Given this list of marker genes ALDH5A1, RFC3, LHFPL6, SLC35E3, LEF1, HADH, BMP7, RCBTB1, HNRNPA3, DLEU1, NASP, RAP1GAP2, FHOD3, PTBP2, WASF1, MME, RGCC, PDCD4-AS1, TUBB2A, TCF3, APBB2, SUGCT, BACH2, TCL6, ID3, CSE1L, SOX11, TFDP2, SERINC5, TERT, TUBA1A, SSBP2, RNASEH2B, NSG1, VPREB1, PRDM10, PRKAR2B, ATP5MJ, LZTS1, SMARCA4 (NCBI Gene Id 6597), UCHL1, TUBB2B, TCP1, here is a description of the gene set: BACKGROUND: The distinction between Burkitt's lymphoma and diffuse large-B-cell lymphoma is unclear. We used transcriptional and genomic profiling to define Burkitt's lymphoma more precisely and to distinguish subgroups in other types of mature aggressive B-cell lymphomas. METHODS: We performed gene-expression profiling using Affymetrix U133A GeneChips with RNA from 220 mature aggressive B-cell lymphomas, including a core group of 8 Burkitt's lymphomas that met all World Health Organization (WHO) criteria. A molecular signature for Burkitt's lymphoma was generated, and chromosomal abnormalities were detected with interphase fluorescence in situ hybridization and array-based comparative genomic hybridization. RESULTS: We used the molecular signature for Burkitt's lymphoma to identify 44 cases: 11 had the morphologic features of diffuse large-B-cell lymphomas, 4 were unclassifiable mature aggressive B-cell lymphomas, and 29 had a classic or atypical Burkitt's morphologic appearance. Also, five did not have a detectable IG-myc Burkitt's translocation, whereas the others contained an IG-myc fusion, mostly in simple karyotypes. Of the 176 lymphomas without the molecular signature for Burkitt's lymphoma, 155 were diffuse large-B-cell lymphomas. Of these 155 cases, 21 percent had a chromosomal breakpoint at the myc locus associated with complex chromosomal changes and an unfavorable clinical course. CONCLUSIONS: Our molecular definition of Burkitt's lymphoma clarifies and extends the spectrum of the WHO criteria for Burkitt's lymphoma. In mature aggressive B-cell lymphomas without a gene signature for Burkitt's lymphoma, chromosomal breakpoints at the myc locus were associated with an adverse clinical outcome. from publication Hummel M, Bentink S, Berger H, Klapper W, Wessendorf S, Barth TF, Bernd HW, Cogliatti SB, Dierlamm J, Feller AC, Hansmann ML, Haralambieva E, Harder L, Hasenclever D, Kühn M, Lenze D, Lichter P, Martin-Subero JI, Möller P, Müller-Hermelink HK, Ott G, Parwaresch RM, Pott C, Rosenwald A, Rosolowski M, Schwaenen C, Stürzenhofecker B, Szczepanowski M, Trautmann H, Wacker HH, Spang R, Loeffler M, Trümper L, Stein H, Siebert R, Molecular Mechanisms in Malignant Lymphomas Network Project of the Deutsche Krebshilfe (PMID 16760442) studied in species Homo sapiens Human Gene Set: HUMMEL_BURKITTS_LYMPHOMA_UP Up-regulated genes constituting the molecular signature of Burkitt 's lymphoma.